The following is a description of a gene set: from publication Iparraguirre A, Tobias JW, Hensley SE, Masek KS, Cavanagh LL, Rendl M, Hunter CA, Ertl HC, von Andrian UH, Weninger W (PMID 18029397) Human Gene Set: GSE7831_UNSTIM_VS_CPG_STIM_PDC_4H_DN studied in species Homo sapiens Genes down-regulated in plasmacytoit dendritic cells (4h): untreated versus CpG oligodeoxynucleotide 1826. CpG 1826 binds to Toll-like receptor (TLR)9, whereas influenza virus PR8 activates pDC via TLR7. Differential stimulation of pDCs is expected to result in unique activation mechanism(s) leading to a different phenotypically and functionally matured pDC We used microarrays to detail the global programme of gene expression underlying the maturation process of pDC activated with CpG 1826 and influenza virus PR8. We identified a distinct expression profile of upregulated immunomediators., and this is the list of marker genes: PPP1R17, GRIK1, STX7, PSAP, ERP29, RRBP1, SSR1, TRPC6, CSF2RB, TMEM208, HIVEP1, SH3BGR, FBXW5, DNASE1L1, IRF5, PON3, HLA-DRB1, RAI2, CASK, TUBB2A, MYO5A, POMP, TCIRG1, ITM2B, SCPEP1, SPIN1, ST6GAL1, HLA-E, RELL1, MTDH, SMIM14, IGF1R, SLC4A4, SELENOS, GCOM1, RHPN1, SPSB1, FES (FES proto-oncogene, tyrosine kinase), RLN1, SLC6A1, GLRX3, NEK6, ARID3A, CANT1, HAS1, DAP, GLTP, LGALS1, RIOX2, DUSP9, TMEM266, SFRP4, P3H3, ZDHHC6, CDKN2D (NCBI Gene Id 1032), MRPL37, DPM3, MRPS5, CEACAM21, MYCL, TLR7, ALB, NUCB2, BMP6, RGN, CTSH, SPNS1, METTL1, CTNND2, NAGA, COX16, SUMF1, EBP, PCP2, WDR13, HPS4, RAD51B, ATP2A1, HSD17B11, TRIM25, PIP4K2A, PCYT2 (phosphate cytidylyltransferase 2, ethanolamine), PAFAH1B3, LDHB, GSN, BARX2, FDPS, NOP16, ST6GALNAC1, PEPD, ITM2C, HLA-DMB, NTPCR, SSTR3, GNA11 (G protein subunit alpha 11), OCEL1 (occludin/ELL domain containing 1), GNAZ, MAP7D1, COP1, MSH5, WFDC2, SLC8A1, ISG15, FAM111A, ACIN1, STK11, ADAM28, MAN2C1, PRDX1, B3GALT2, HADH, ZFYVE19, HCFC1R1, ATP5MF, MPEG1, ICAM5 (intercellular adhesion molecule 5), NAMPT, ALG2, ETV1, PTK2, TLX3, HLA-DMA, BCKDK, BCKDHB, ANKS3, SPINT1, FGGY, RGS14, ATRAID, SIRPA, ITGB7, UROS, SEC11C, FLNB, RYR2, FCRLA, ANAPC5, GLCE, CDKL2, CYP7B1, CXCR3, SLC25A28, TRMT2A, HEXA, ACVR2B, HINT2, DDR1, MECR, GFER (growth factor, augmenter of liver regeneration), FMNL3, HLA-DOA, RAMP1, ZMIZ2, LYST, TIMP1, SNAP91, NSDHL, GPM6B, ACTR1B, GCM1, GAS7, UBXN4, CEBPD, SVIL, AMFR, TOX4, PKP3, NAPSA, SLPI, FOXK1 (forkhead box K1), HLTF, PACSIN1, EPCAM, COA6, SFRP1, CLVS1, UNC93B1, ZDHHC14, USP18, PLD4, PLS3, NXN, TRPV2, GSTT1, PSMC5, CMKLR1, C11orf54, BLNK, ZNF398 (zinc finger protein 398), HERPUD1, ST3GAL1, CLIC4, RPN2, PPTC7, ADAMTS1, UBFD1, SCARB2, LDLR, CLIP3, FBXW4